The following is a description of a gene set: species: Homo sapiens The process in which a CD4-positive, alpha-beta T cell becomes committed to becoming a T-helper cell, a CD4-positive, alpha-beta T cell specialized to promote various immunological processes. Human Gene Set: GOBP_T_HELPER_CELL_LINEAGE_COMMITMENT, and this is the list of marker genes: EP300, BATF, SPN, STAT3, TNFSF18, IL6R, TBX21, SLAMF6 (NCBI Gene Id 114836), JAK1, IL6, IL23A, IL12RB1, LGALS1 (NCBI Gene Id 3956), IL23R (interleukin 23 receptor), CD69, STAT5A, ZFPM1, LY9, SOCS3, OPA1, IL12B, JAK3, BRD2, BRD4, IL6ST (interleukin 6 cytokine family signal transducer), MTOR, STAT6, IRF4, LOXL3